The following is a description of a gene set: Mouse Gene Set: MIR_3065_3P Genes predicted to be targets of miRBase v22 microRNA mmu_miR_3065_3p in miRDB v6.0 with MirTarget v4 prediction scores > 80 (high confidence targets). studied in species Mus musculus from publication Chen Y, Wang X (PMID 31504780), and this is the list of marker genes: Vamp3, Nav1, Kdm5a, Vwc2l, Zfp865, Arrdc3, Dbt (dihydrolipoamide branched chain transacylase E2), Dtx4, Apaf1, Pak3, Agfg1, Gphn, Lasp1, Tmem183a, Tmem169, Naa40, Rdh9, Cox10, Bicd1, Enpp2, Senp1, Col4a3, Cemip, Ccng2, Klhl9, Frem1, Creb1, Lox, Nfat5, Mfsd14b, Myl6, Gpc2, Hnrnpul2, U2surp, Maml3, Tsc22d3, Mtpn, Mier3, Mest, Ap1g1, R3hdm1, Hic2, Slc7a15, Hbegf, Osbp, Zbtb10 (NCBI Gene Id 99802), Gnao1, Acvr2b, Xkr6, Angptl4, Fam135a, Dnajc27, Hapln1, Tsen15, Prkra, Fbxo41, Nav3, Psme4, Erap1 (endoplasmic reticulum aminopeptidase 1), Piga, Degs2, Ric8a, Jarid2, Ehmt1 (NCBI Gene Id 77683), Hnf4g, Acap3, Dio2, Col5a3, Pcsk5, Cd2ap, Ulk1, Serpinh1, Rbm8a, Foxred1 (NCBI Gene Id 235169), Zbtb34, Zfp827, Tnrc18, Prkn, Ppm1d (NCBI Gene Id 53892), Emid1, Pcyt1b, Dot1l, Dok4, Mctp2, Csrnp3, Col24a1, Gpr101 (G protein-coupled receptor 101), Wac, Fkbp1a, Klhl8, Nsd2, Cep15, Zfp113, Tspan14, Trib2, Sidt1, Garre1, Mmp2, Ppp4r3b, Ing4, Fbxw9, Ss18l1, Myadm, Ing2, Tet2, Chmp6, Pdhx, Slc30a10, Igsf9b, Cttnbp2nl, Grm4, Fubp1, Nav2, Itga5, Gjb3, Kndc1, Prrc2c, Armc8, Scfd2, Rnf150, Cpeb3, Spty2d1, Sh3rf3, Adhfe1, Pten, Il1rapl2, Dusp22, Slc30a3, Nfatc3, Prrt4, Galnt6 (polypeptide N-acetylgalactosaminyltransferase 6), Rbfox2, Snx4, Commd2, Col7a1, Mkrn1, Birc6, Nfkb1, Stag2, Aptx, Hmgcs1, Smpd3, Wdfy1, Camk2g, Bcl7a, Ppp1r3d, Pank1, Wdr26, Fam168a, Kiss1r, Lmtk2, Nasp, Msl2, Cacna1e (NCBI Gene Id 269133), Ephb3, Hmcn1, Pex19, Spats2l, Ubtd2, Isl1, Gpr17, Arap1, Hepacam, Ccnd2, Arvcf, Adamts17, Blmh, Mxd1, Gid8 (GID complex subunit 8), Slc27a4, Eva1a, Prr3, Med12l, Ankrd49, Tet3, Hnrnpul1, Pacs2, Fras1, Rock1, Fam184b, Pthlh, Efna2, Tet1, Ctns (cystinosis, nephropathic), Cpd (carboxypeptidase D), Ppard, Cpe, Stk35, Slc7a5, Retreg3, Gab1, Pradc1, Col11a1, Ccr9, AI593442, Mapkbp1, D630039A03Rik, Col5a1, Bdnf, Capn5, Lmnb1, Agpat4, Elovl5, Kdm2a (NCBI Gene Id 71431), Eml4, Asxl3, Adamts15, Plppr4, Epha1